The following is a description of a gene set: Human Gene Set: MIR3154 from publication Chen Y, Wang X (PMID 31504780) Genes predicted to be targets of miRBase v22 microRNA hsa-miR-3154 in miRDB v6.0 with MirTarget v4 prediction scores > 80 (high confidence targets). species: Homo sapiens, and this is the list of marker genes: TP53INP2, ADRB3, SOCS2, ZNF783, CALCA, CES4A, CPEB2, FAM181B, KMT2B, PIANP, ELAVL1, SPTSSA, NINJ2, MEIS3, PPARG, C1orf226, CLIC5, HCFC1, KCNQ5, GGA2, CLOCK, NUP43, INO80D, CDK2, ZFP28, GIGYF2, POU2AF1, TERF2, SRP19 (signal recognition particle 19), LIN54, EPB41L2, BCL2L13, SFXN3, RBM18, KIAA0513, APPL1, ARF3, EVA1C, CCNG2, CTSC, ARMC3, ZSCAN9, KMT2C, SMAD3, CCT6B, HMGN2, GRIN2B, HIPK3, POU3F4, URM1, MBIP (MAP3K12 binding inhibitory protein 1), SRD5A1, LINGO1, KY, ZNF697, SPRY3, CD84, CAMKV (CaM kinase like vesicle associated), FAM76A (family with sequence similarity 76 member A), ADPRHL1, NOVA2, CTCF, CCDC191, TRIM5, SPATA33, MECP2, CDC42, RBM8A, MED20, CMTM7, NRXN1, LURAP1L, OST4, COX15, SLC31A1, TLK1, AFDN, GPAT2, SCAMP5, FEZ2, ZNRF1, RORA, C20orf96, CAMK1D (calcium/calmodulin dependent protein kinase ID), POU2F1, LARP1, CNTNAP2, SORCS1, ZSWIM4, ZNF219, FHL1, SLC6A19, NFIX, RSPH3, ASCC3, ZBTB20, NAGA, RAD51C, TRMT5, TTBK2, TMEM170B, SLC25A15, GML, RUNX2, SKP1, EVI2A, ACP7, NPEPPS, CCR4, SOX8, TFCP2L1, DPF2, PPP1R11, NPL, HOXB8 (homeobox B8), UBE2L6